Given this list of marker genes TOP2A, MNAT1, IFNGR1, DDIT3, CLK1 (CDC like kinase 1), CCNB1, PTK2, MYCL, MYBL2, HSPD1, USP4, ZFP36, SMARCA1, SGPL1, CSDE1, HSF2, KRT5, RASA1, PIK3CA, WT1, CFLAR, FAS, here is a description of the gene set: from publication Yih LH, Peck K, Lee TC (PMID 12016162) Arsenic compounds are widely distributed and arsenic ingestion is associated with many human diseases, including blackfoot disease, atherosclerosis, and cancers. However, the underlying mechanism of arsenic toxicity is not understood. In human fibroblast cells (HFW), arsenite is known to induce oxidative damage, chromosome aberrations, cell cycle arrest, and aneuploidy, and the manifestation of these cellular responses is dependent on changes in gene expression which can be analyzed using the cDNA microarray technique. In this study, cDNA microarray membranes with 568 human genes were used to examine mRNA profile changes in HFW cells treated for 0 to 24 h with 5 microM sodium arsenite. On the basis of the mean value for three independent experiments, 133 target genes were selected for a 2 x 3 self-organizing map cluster analysis; 94 were found to be induced by arsenite treatment, whereas 39 were repressed. These genes were categorized as signal transduction, transcriptional regulation, cell cycle control, stress responses, proteolytic enzymes, and miscellaneous. Significant changes in the signaling-related and transcriptional regulation genes indicated that arsenite induces complex toxicopathological injury. Genes in cluster 1: strongly up-regulated in HFW cells (fibroblast) upon treatment with sodium arsenite at all time points. Human Gene Set: YIH_RESPONSE_TO_ARSENITE_C1 studied in species Homo sapiens